Given this list of marker genes CCM2, PIK3CA, KRIT1 (NCBI Gene Id 9602), PDCD10, ATP2B1, here is a description of the gene set: Cerebral cavernous malformation species: Homo sapiens Human Gene Set: HP_CEREBRAL_CAVERNOUS_MALFORMATION A cerebral cavernous malformation (also known as cavernoma, cavernous angioma, cavernous hemangioma) is a collection of structurally abnormal slow-flow capillaries predominantly in the central nervous system. These are multiple mulberry-like distended caverns of dilated thin-walled capillaries without the normal intervening brain parenchymal architecture. Often, individual cavernomas are surrounded by hemosiderin representing remote oozing due to the abnormal capillaries.